The following is a description of a gene set: Any process that results in a change in state or activity of a cell (in terms of movement, secretion, enzyme production, gene expression, etc.) as a result of a sodium arsenite stimulus. Human Gene Set: GOBP_CELLULAR_RESPONSE_TO_SODIUM_ARSENITE studied in species Homo sapiens, and this is the list of marker genes: ZC3H12A, MAPK13, HNRNPA1, DAXX, HSF1